Given this list of marker genes PTPN22, RIOK3, CPTP, PYDC1, TREM2, RNF39, F2RL1, PPT1, TRIM65, MEFV, IFI16 (NCBI Gene Id 3428), CARD8, MARCHF5, AKT1, FBXL2, PYDC2, MIR4691, TRIM31, UBQLN1, NLRX1, PRKDC, NLRP2B, TRIM11, RAB7B, ITCH, OGT, TNFAIP3, TAX1BP1, PPP6C, LAMP2, ZDHHC18, PYDC5, ABHD17A, NLRC3, GRAMD4, CSNK1A1, PTPRS, HSPA8, CGAS, UFD1, ERBIN, DHX58, ABHD8, SIRT2, TSPAN6, GPATCH3, IRGM, SPSB3, LILRA4, ZNRF4, SMPDL3A, TREX1, NPLOC4, AURKB, LYPLAL1, TARBP2 (TARBP2 subunit of RISC loading complex), PCBP2, RNF125, BANF1, ZDHHC12, TKFC, C1QBP, PARP1, SEC14L1, AARS2, here is a description of the gene set: species: Homo sapiens Human Gene Set: GOBP_NEGATIVE_REGULATION_OF_CYTOPLASMIC_PATTERN_RECOGNITION_RECEPTOR_SIGNALING_PATHWAY Any process that stops, prevents, or reduces the frequency, rate or extent of the series of a cytoplasmic pattern recognition receptor signaling pathway.